Given this list of marker genes INPP5A (inositol polyphosphate-5-phosphatase A), BECN2, SLIT2, GRK2, PALM, RGS4, APELA, ARRB1, BICD1, RGS2, PPP3CA, ARRDC3, MIR20A, SNCA, GIPR, PLD2, SAG, PADI2, UBQLN2, DRD2, APLNR, MRAP, MET, PLEK, STMN1, MRAP2, MIR101-1, KLK14, RGS13, NECAB2, ADRB2, RPGRIP1L, DRD3 (dopamine receptor D3), GRK3, APLN, ADRB3, ARR3, RGS7, RGS14, CALCA, GNAI2, PDE4B, PDE3B, CXCL8, RNF113A, PDE4D, PDE2A, SLIT3, CRTC3, APLP1, ATP2B4, GTF2H2, GRM5, ROBO1, APP, CRY1, ARRB2, CCL5, ADA, RPH3AL, YWHAB, GPRASP1, MGRN1, SH2B3, ADM, PDE3A, here is a description of the gene set: Human Gene Set: GOBP_NEGATIVE_REGULATION_OF_G_PROTEIN_COUPLED_RECEPTOR_SIGNALING_PATHWAY species: Homo sapiens Any process that stops, prevents, or reduces the frequency, rate or extent of G protein-coupled receptor signaling pathway.